Given this list of marker genes NTRK2, BDNF, here is a description of the gene set: Reactome Pathway: BDNF activates NTRK2 (TRKB) signaling species: Homo sapiens part of: Signaling by NTRK2 (TRKB) Signaling by the neurotrophin receptor tyrosine kinase NTRK2 (TRKB) can be activated by binding to brain-derived neurotrophic factor (BDNF), which functions as a ligand for NTRK2. Binding to BDNF triggers NTRK2 dimerization and trans-autophosphorylation of NTRK2 dimers on conserved tyrosine residues in the cytoplasmic tail of the receptor. Phosphorylated tyrosine residues subsequently serve as docking sites for recruitment of effector proteins that trigger downstream signaling cascades.